The following is a description of a gene set: Human Gene Set: GSE17580_TREG_VS_TEFF_S_MANSONI_INF_UP species: Homo sapiens Although several markers have been associated with the characterization of regulatory T cells (Treg) and their function, no studies have investigated the dynamics of their phenotype during infection. Since the necessity of Treg to control immunopathology has been demonstrated, we used the chronic helminth infection model S. mansoni to address the impact on the Treg gene repertoire. Before gene expression profiling we first chose to study the localization and antigen-specific suppressive nature of classically defined Treg during infection. Presence of Foxp3+ cells were found especially in the periphery of granulomas and isolated CD4+CD25hiFoxp3+ Treg from infected mice blocked IFN-gamma and IL-10 cytokine secretion from infected CD4+CD25- effector T cells (Teff). Furthermore the gene expression patterns of Treg and Teff showed that in total genes were significantly regulated during chronic schistosomiasis. Upon k-means clustering we identified genes exclusively regulated in all four populations including Foxp3, CD103, GITR, OX40 and CTLA-4: classical Treg markers. During infection however, several non-classical genes were up-regulated solely within the Treg population such as Slpi, Gzmb, Mt1, Fabp5, Nfil3, Socs2, Gpr177 and Klrg1. Using RT-PCR we confirmed aspects of the microarray data and in addition showed that the expression profile of Treg from S. mansoni-infected mice is simultaneously unique and comparative with Treg derived from other infections from publication Layland LE, Mages J, Loddenkemper C, Hoerauf A, Wagner H, Lang R, da Costa CU (PMID 20007528) Genes up-regulated in comparison of regulatory T cell (Treg) from mice infected with S. mansoni versus T effector cells from the infected mice., and this is the list of marker genes: C1QTNF12, MT1E, SLC52A3, ECM1, MATN2 (NCBI Gene Id 4147), EHD4, ITIH5, CXCL3, MKLN1 (NCBI Gene Id 55782), TNFRSF13B, B4GALT4, CASP3, UAP1, BCL2L15, GCSH, APOBEC1 (apolipoprotein B mRNA editing enzyme catalytic subunit 1), IGF2R, MDFIC, NAF1, PLSCR1, PTGER2, PDZK1IP1, ST14, FBXW11, TDRD7, PTDSS2, TUBG1, MAGI1, MTHFD1, ICA1, IL2RA, PDE8A, TMEM158, CD2, NRDC, NCMAP, NOC4L, PLP2, LRIG1, IRF5, HTRA2, TIRAP (NCBI Gene Id 115469), LTA, SLC2A3, BCAT1, ODC1, TNFRSF9, GZMB, GOT2, PPP3CA (protein phosphatase 3 catalytic subunit alpha, NCBI Gene Id 5530), MIF4GD, IKZF4, FOSB, ARHGEF12, MBNL3, HOPX, PRDM5, PARP12, ITGAE (integrin subunit alpha E), GJB2, PDCD1LG2, UHRF1, PRDM1, PRKRA, PHTF2, PIP5K1B, GSTO1, WLS, CAPN5, PENK, CPQ, METAP2 (methionyl aminopeptidase 2), MED7, SMYD2, CD81, IMMP2L, NUP155, ALCAM, MCM5, SWAP70, FAM174B, CTLA4, GPR83, PTPRJ, PPP6R3, ARMCX4, TSPAN12, HSD3B7, LAMC1, NIBAN2, EIF4E3, FUCA2, LRRC57, CCR6, EIF4EBP1, TMEM109, PYCR3, TXN, POLE, ARL6IP1, FARSB, VAV3, EPCAM, ALDOC, POGLUT2, TGM2, HM13, CNTLN, IFT80, CD79B, ERI1, PHLDA1, AXL, CSRP2 (cysteine and glycine rich protein 2), QNG1, YWHAE, SOCS2, RAD51B, SLAMF1, SLC22A5, KLHDC4, CD83, IL10RB (interleukin 10 receptor subunit beta), SLC35D1, PRELID3B, DBNDD2, TNFRSF18, SEC14L2, CD86, GRB7, GNB4, SCAMP1, PRNP, AREG, VPS54, KLRG1, COMT, CCRL2, SLC9B2, ENTPD1, ZCCHC18, HBEGF, SDHAF1, CD200, CORO2A, LIF, CERK, NIBAN1, FOXP3, CCR8, SERPINC1, POLE3, EBI3, TRPC3, DCLRE1A, GBP4, FAH, IL18, CAPG, RGS9, DENND5A, WWP1, BRCA1, CYB561, DNPEP, H2AZ1, SCRN2, SNX9, HEMK1, MCM4, CHTF18, RIPK3, B9D1, GATA1, ARRDC4, RAB31, NAT9, TGFBR1, PTRH2, SCIN, CMTM7 (CKLF like MARVEL transmembrane domain containing 7), RGS1, DNAJC1, GABARAPL1, PLXND1, ANXA4, BATF, IGSF9, TBRG1, SELENOM, AHCYL2, SNAP23, SERPINB9, PMEPA1, SSBP3 (single stranded DNA binding protein 3), TLR7, HMGN3, BID, SNAI2, ERI2 (NCBI Gene Id 730570)